The following is a description of a gene set: Any process that modulates the frequency, rate or extent of leukocyte tethering or rolling. Mouse Gene Set: GOBP_REGULATION_OF_LEUKOCYTE_TETHERING_OR_ROLLING species: Mus musculus, and this is the list of marker genes: Fut7, Chst2 (carbohydrate sulfotransferase 2), Fut9, Ccr2, Cxcl12, Ccl21e, Ptafr, Itga4, Ccl21d, Ccl28 (NCBI Gene Id 56838), St3gal4, Capn1, Ccl21b, Sele, Ccl21a, Chst4, Ccl21f, Gp1ba, Elane, Fut4, Ccl25, Gcnt1, Pawr, Selp